The following is a description of a gene set: studied in species Mus musculus Mouse Gene Set: chr13B3, and this is the list of marker genes: Habp4, Selenok-ps4, Zfp58, 1810034E14Rik, Mir23b, Gm3785, 1700015C15Rik, Gm46427, Gm7768, Vmn2r-ps102, Cbx3-ps4, Zfp640, Gm10323, Gm36501, Gm19792, Gm45965, Zfp808, Prss47, Mfsd14b, Hsd17b3, 4930525G20Rik, Nlrp4f, Vmn2r-ps109, Gm46440, Zfp367, Zfp953, Fam240b (family with sequence similarity 240 member B), Gm7911, Gm7712, Gm40983, Gm7822, Zfp87, Cfap90, Gm7762, Gm49399, Vmn2r-ps106, Vmn2r-ps98, Gm4810, Gm40987, Gm10769, Zfp935, Gm53057, Rslcan18, Zfp457, Gm40989, Fbp1, Ptch1, Gm9894, Gm3333, A930032L01Rik, Gm4812, Mtrr, Gm3325 (predicted gene 3325), AA414992, Zfp595, Gm6478, Spata31d1c, 1700024I08Rik, Fbp2, Gm17938, Ctsl, Zfp997, Gm21930, Gm5141, Gm48116, Zfp999, Mir24-1, Gm48691, Zfp493, Mir27b, Gm16133, Ercc6l2 (NCBI Gene Id 76251), Gm5451, Vmn2r-ps108, Hmgb1-ps11, Gm3604, Uqcrb, C330022B21Rik, Prxl2c, Zfp874a, Zfp998, Gm7049 (predicted gene 7049), Selenok-ps8, Gm4811, Gm30709, Zfp729a, Gm7664, Zfp85os, Vmn2r-ps97, Selenok-ps6, Gm36298, Mterf3, Zfp458, Gm38428, Or9s18, Zfp429, Gm7928, Slc35d2, Gm17039, Zfp1008, Gm31218, Selenok-ps5, Zfp455, Cbx3-ps2 (NCBI Gene Id 118568054), Krbox5, Gm19118, Fancc, Gm7065, Gm7979, Gm10775, Cdk20, Platr25, Zfp65, Gm40988, 9430065F17Rik, Gm6436, Gm3829, Zfp456, Gm30655, Fastkd3, Zfp369, Gm7045, Or14p1, Ptdss1, Vmn2r-ps95, Gm9625, Zfp874b, Gm35619, Rybp-ps, BC048507, F630042J09Rik, Gm9626 (NCBI Gene Id 674699), Gm3338, Ramacl, Cntnap3, Gm6888, Cbx3-ps1, Aopep (NCBI Gene Id 72061), Vmn2r-ps104, Tent4a, Cbx3-ps5 (NCBI Gene Id 544944), Vmn2r-ps96, Gm7240, Gm3800, Gm26806, A530095I07Rik, Gm24130, Vmn2r-ps100, Gm18260, Zfp273, Gm46424, Zfp712, Vmn2r-ps99, Vmn2r-ps103, Zfp738, Gm36445, Cdc14b, Gm7969, 4933433G19Rik, Gm21963, Rsl1, Zfp1000, Gm8016, Gm19119, Mir3074-1, Gm5791, Spata31, Gm26844, Gm49400 (predicted gene 49400), Gm35161, Vmn2r-ps105, Gm23855 (NCBI Gene Id 115485921), Zfp708, Zfp759, Zfp729b, Nsun2, Zfp459, Zfp85, Gm7896, Adcy2, Zfp934, Gm35514 (NCBI Gene Id 102639128), Gm4935, Eif1-ps2, Gm40977, Gm7695, Zfp748, Gm30409